The following is a description of a gene set: Polo-like kinase mediated events Mouse Gene Set: REACTOME_POLO_LIKE_KINASE_MEDIATED_EVENTS species: Mus musculus, and this is the list of marker genes: Wee1, Plk1, Pkmyt1, Cdc25c, Foxm1